Given this list of marker genes LIN7B, LIN7A, SIX1, SIX4, AGRN, PDZD11, COLQ, LIN7C, MYCBP2, MUSK, here is a description of the gene set: Any process that modulates the frequency, rate or extent of synaptic assembly at neuromuscular junctions. Human Gene Set: GOBP_REGULATION_OF_SYNAPTIC_ASSEMBLY_AT_NEUROMUSCULAR_JUNCTION studied in species Homo sapiens